Given this list of marker genes SRP54, TRPV4, DNAJC21, COL10A1, UFSP2, CFAP410, KIAA0586, CSPP1, SBDS (SBDS ribosome maturation factor), here is a description of the gene set: An anomaly of the metaphysis of the proximal femur (close to the hip). Abnormal proximal femoral metaphysis morphology Human Gene Set: HP_ABNORMAL_PROXIMAL_FEMORAL_METAPHYSIS_MORPHOLOGY species: Homo sapiens